Given this list of marker genes CMPK2, MYD88, MT-TH, VHL, CLIP2, PRNP, ACTG1, MPL, TTR (NCBI Gene Id 7276), TGFB2, MT-TW, PLIN1, VPS37D, TNNI3, SNORD118, ACTB, GNB2, HBB, BAZ1B, CBS, NDUFA8, CALR, SLC2A10, APP, ATRX, COL4A1, GUCY1A1, TGFBR1, METTL27, MT-TK (NCBI Gene Id 4566), OTC (NCBI Gene Id 5009), TBX20, MT-TL1, ENG, COL3A1, ANO1, PMM2, PCNT, SMAD4, MT-TC, CITED2, PNP, HEY2, MT-CYB, BRAF, TANGO2, HSD11B2, GNAQ, MMUT, LOX, AMACR, WFS1, SMARCAL1, DPAGT1, F2, NAGA, TMEM106B, TP53, BRCC3, RFC2 (replication factor C subunit 2), PIK3C2A, ADA2, MT-CO3, MT-TF (mitochondrially encoded tRNA-Phe (UUU/C)), ERCC6, DPM3, HTRA1, FHOD3, ZAP70, LRPPRC, MTHFR, ACTC1, NOTCH3, VCP, FLNA, KRAS, CST3, ENPP1, TREM2, GRN, LIG3, MT-TV, IL12B, GYS1 (glycogen synthase 1), TGFBR3, GTF2IRD2, ASS1, DYRK1B, USP48, SMAD3, STIM1, PRKG1, SH2B3, ERCC8, TMEM270 (transmembrane protein 270), RNF213, SMAD2, TREX1, PRKCH, MT-CO1, MYH7, BUD23, CCND1, NR3C1, TNNT2, MECP2, GATA6, ACAD9, AGXT, MYH6, ACTA2, MT-ND6, RFT1, MYLK, MAT2A (methionine adenosyltransferase 2A), TRPV6, MYBPC3, NPPA, F5, MT-TS2, ANGPTL6, CCM2, NAGS, ACVRL1, TPP2, MLXIPL, THPO, TLL1, ELN, CHMP2B, THSD4, GTF2I, KIF20A, EFEMP2, HLA-B, JAK2, ADAMTS13, PIGA, B3GALT6, FBN1, EIF4H, SLC19A2, GDF2, TBL2, PRKAR1A, NOS3, JAG1, NF1, GTF2IRD1, MYPN, XYLT2, TGFB3, USP8, MT-ND4 (NCBI Gene Id 4538), CDH23, PSEN1, CPS1, MT-ND5, MLX, COLGALT1, SCN5A, TET2, THSD1, ABCC6, GATA4, NCF1, MFAP5, NKX2-5, SON (SON DNA and RNA binding protein), ALOX5AP, XYLT1, LIMK1, STX1A, GLA, MMACHC, MT-CO2, FLNC, FOXE3, MYH11 (myosin heavy chain 11), PDE11A, MT-TQ, FKBP6, TNXB, MT-ND1, SNAP29, ZMPSTE24, MAPT, LMNA, DNAJC30, TGFBR2, here is a description of the gene set: species: Homo sapiens Sudden impairment of blood flow to a part of the brain due to occlusion or rupture of an artery to the brain. Stroke Human Gene Set: HP_STROKE